Given this list of marker genes Lyst, Ap3d1, Atg14, Epg5 (ectopic P-granules 5 autophagy tethering factor), Rab7b, Vps41, Tsg101, Stx8 (syntaxin 8), Plekhf2, Gprasp1, Dtx3l, Snx16, Trak1 (trafficking protein, kinesin binding 1), Mvb12a, Hook1, Ubxn6, Snapin, Tgfbrap1, Chmp6, Vps39 (VPS39 HOPS complex subunit), Tpcn2, Rab7, Vps11, Dennd3, Pcdhga3, Arl8b, Hook3, Chmp4c, Vps18, Rhob, Snx27, Cdx2, Plekhf1, Hook2, Chmp7, Vps4a, Uevld, Chmp2b, Chmp3, Fhip1b, Trak2, Vcp, Vps16, Mtm1, Mgrn1, Chmp5, Chmp1a, Vipas39, Stx7, Chmp1b2, Rilp, Vps4b, Lipa (NCBI Gene Id 16889), Chmp2a, Scyl2, Sort1, Bin1, Rab12, Aktip, Chmp1b, Kif13a, Rufy4 (RUN and FYVE domain containing 4), Chmp4b, Hgs, Becn2, Vps33a, here is a description of the gene set: studied in species Mus musculus Mouse Gene Set: GOBP_ENDOSOME_TO_LYSOSOME_TRANSPORT The directed movement of substances from endosomes to lysosomes.